The following is a description of a gene set: species: Homo sapiens Human Gene Set: GOMF_MELANOCORTIN_RECEPTOR_ACTIVITY Combining with melanocortin to initiate a change in cell activity., and this is the list of marker genes: MC3R, MC4R, MC1R, MC5R, MC2R, OPRM1